Given this list of marker genes NANOS3, KIT, PRDM1, BCL2L2, WT1, STRA8, SMAD1, GJA1, WNT4, BCL2, TIAL1, ZFX, GCG, TCF21, DAZL, BMP4, SMAD5, BMP8B, FST, here is a description of the gene set: studied in species Homo sapiens Genes important for embryonic germ cell, based on mouse models with female fertility defects. Reproduction is required for the survival of all mammalian species, and thousands of essential 'sex' genes are conserved through evolution. Basic research helps to define these genes and the mechanisms responsible for the development, function and regulation of the male and female reproductive systems. However, many infertile couples continue to be labeled with the diagnosis of idiopathic infertility or given descriptive diagnoses that do not provide a cause for their defect. For other individuals with a known etiology, effective cures are lacking, although their infertility is often bypassed with assisted reproductive technologies (ART), some accompanied by safety or ethical concerns. Certainly, progress in the field of reproduction has been realized in the twenty-first century with advances in the understanding of the regulation of fertility, with the production of over 400 mutant mouse models with a reproductive phenotype and with the promise of regenerative gonadal stem cells. Indeed, the past six years have witnessed a virtual explosion in the identification of gene mutations or polymorphisms that cause or are linked to human infertility. Translation of these findings to the clinic remains slow, however, as do new methods to diagnose and treat infertile couples. Additionally, new approaches to contraception remain elusive. Nevertheless, the basic and clinical advances in the understanding of the molecular controls of reproduction are impressive and will ultimately improve patient care. Human Gene Set: MATZUK_EMBRYONIC_GERM_CELL from publication Matzuk MM, Lamb DJ (PMID 18989307)